Given this list of marker genes SIRT4, GSTZ1, PDPR, DLAT, PDK1, DLD, PDK4, PDP1, PDHA1, PDK2, PDHA2, PDHB, PDK3, PDP2, PDHX, here is a description of the gene set: part of: Regulation of pyruvate metabolism The mitochondrial pyruvate dehydrogenase (PDH) complex catalyzes the oxidative decarboxylation of pyruvate, linking glycolysis to the tricarboxylic acid cycle and fatty acid synthesis. PDH inactivation is crucial for glucose conservation when glucose is scarce, while adequate PDH activity is required to allow both ATP and fatty acid production from glucose. The mechanisms that control human PDH activity include its phosphorylation (inactivation) by pyruvate dehydrogenase kinases (PDK 1-4) and its dephosphorylation (activation, reactivation) by pyruvate dehydrogenase phosphate phosphatases (PDP 1 and 2). Isoform-specific differences in kinetic parameters, regulation, and phosphorylation site specificity of the PDKs introduce variations in the regulation of PDC activity in differing endocrine and metabolic states. Further, PDH is inhibited by SIRT4 and the drug dichloroacetic acid (DCA). species: Homo sapiens Reactome Pathway: Regulation of pyruvate dehydrogenase (PDH) complex